The following is a description of a gene set: Human Gene Set: GOBP_REGULATION_OF_NERVOUS_SYSTEM_PROCESS Any process that modulates the frequency, rate or extent of a neurophysiological process, an organ system process carried out by any of the organs or tissues of the nervous system. studied in species Homo sapiens, and this is the list of marker genes: JAM2, GRIN2A, NLGN4X, GBA1, LRRK2, CST7, ZNF488, NCMAP, MTMR2, NTSR1, GRIN2D, DVL1, MIR30B, QKI, CCN3, CHRNA2, UNC13B, PTEN, SMR3A, TNFRSF1B, IGF1, FMR1, NLGN3, GRIN2B, S1PR2, GLRA1, NLGN2, ITGAX, CHRNB4, AVP (arginine vasopressin), LPIN1, TNR, TAFA4, CBLN1, HTR2C, PRKN, TMEM98, NMU, OPRPN, GRIK2, ZMYND8, TNF, SLC8A3, TAC4, FGF12, WASF3, TMEM100 (NCBI Gene Id 55273), SHANK1, FIG4, ADORA1, TMEM25, CELF4, RIMS1, FABP5, NPY2R, NLGN1, NOS3, NRXN1, CHRNA7, ACP3, S100B, DAG1, DLG4, PRKAR1B, SMR3B, RIMS2, ADRB2, GRM1, SOX10, AVPR1A, NRDC, CCL3, RGS4, WNT7A, BAIAP2, TBC1D24, TAC1, GHRL, STX1B, CUX2, ABAT, PTK2B, CTSC, TYMP, MAPK8IP2, GRIN2C, PIRT, DICER1, EIF4A3, GPR171, SHANK3, GRIA1, SPX, TPPP, GRIN1, CDK18, STX1A, GHSR, ATPSCKMT, MAG, ITGA2, ROCK2, TMEM108, NETO1, RELN, MGLL, MTNR1B, ABCB1 (ATP binding cassette subfamily B member 1), RNF10, SSH1, TNFRSF21, HCRT, PRKCZ, TENM4, PARD3, MYRF, ZFHX2, CARTPT, SLC8A2, EIF2AK3, TRPA1, EGR2, DMPK, APP